The following is a description of a gene set: studied in species Homo sapiens part of: Diseases of carbohydrate metabolism Reactome Pathway: Intestinal saccharidase deficiencies Defects in in two enzymes required for intestinal digestion of dietary carbohydrate, lactase (LCT, a domain of lactase-phlorizin hydrolase protein) and sucrase-isomaltase (SI), are annotated here. The first affects nursing infants; the second affects individuals after weaning.<p>The disaccharide lactose is a major constituent of human breast milk. To be taken up from the gut in the nursing infant, this sugar must first be hydrolyzed by LCT present on the external face of enterocytes in microvilli of the small intestine. Mutations that disrupt LCT activity are associated with acute illness in newborn children as lactose fermentation by gut bacteria leads to severe diarrhea. The condition is effectively treated by feeding affected infants a lactose-free formula. This congenital disease is distinct from the down-regulation of LCT expression after weaning in many human populations that is associated with a milder form of lactose intolerance in adults.<p>The starch in a post-weaning diet is digested by amylases to di- and oligosaccharides that must be further digested to monosaccharides in order to be taken up from the lumen of the small intestine into endothelial cells of the intestinal brush border. If they are not digested, a process in which enterocyte-associated SI plays a central role, they remain in the gut lumen and are fermented by gut bacteria, leading to osmotic and fermentative diarrhea., and this is the list of marker genes: SI, LCT